The following is a description of a gene set: Defects in biotin (Btn) metabolism Human Gene Set: REACTOME_DEFECTS_IN_BIOTIN_BTN_METABOLISM species: Homo sapiens, and this is the list of marker genes: HLCS, BTD, PCCB, MCCC2, ACACA, PCCA, PC, MCCC1